The following is a description of a gene set: Genes in the cancer module 105. Human Gene Set: MODULE_105 studied in species Homo sapiens, and this is the list of marker genes: CCL21, SDF2, FGFR1, MKNK1, GBE1, LPIN2, CKS1B, EMG1 (EMG1 N1-specific pseudouridine methyltransferase), UBE2G1, BIRC5, VCAN, PRDX2, CRAT, S100A13, PDXK, PPP4R1, CCNF, PMP22 (peripheral myelin protein 22), DFFA, CDC34, GSPT1, PIGC, CITED2, CSRP2, RRM2, HSPB1, BLM, CTPS1, CITED1, CBR1, ANXA8L1, ADARB1, SLC20A1, COMP, POLD2, MRPL12, ERF, PLIN2, ASNS, MYBL2, UBXN1, NCBP2, THBS2, PCBD1, PFKFB4 (6-phosphofructo-2-kinase/fructose-2,6-biphosphatase 4), EZH2, IGF2BP3, POLR2J, PSMC2, PFKM, HSD17B10, NRIP1, SNX1, MGAT1, LTBR, TCF12, RBP1, SAA1, COL5A2, SNRPB2, GGH, CCNA2, ANXA1, CNN3, GPX2, LRBA, ACOT7, COX17, CARS1, COL4A2, DELE1, LPGAT1, AIMP2, GALC, PMAIP1, RAB4A, ATP2B1, MSMO1, FZD2, SNX17, MAPKAPK3, LMAN2, LAD1, KDM5C, CDK1, PHB1, WASF3, KCNK1 (NCBI Gene Id 3775), P3H4, KNTC1, PYGL, MAN2B1, MALL, FOXM1, GART, SRSF6, PFKP, RPA1, TPBG, TUBG1, FXYD3, CENPA, GTF2H1, PSEN1, HBEGF, SPARC, PCNA, ADAM9 (ADAM metallopeptidase domain 9), IDI1, NEK2, CSF1R, TLR1 (toll like receptor 1), CHAF1A, SREBF2, PPARD, ELAVL1, CLIP1, DDX17, AGXT, ILF3, ALCAM, KEAP1, ATF3, PAICS, PDLIM4, COG2, MELK, ARPC1A, GAS1, ZNF22, LUM, PRPSAP1, RRM1, WEE1, PAFAH1B3, DAP, NOLC1, ACTA2, MAD1L1, UMPS, CDH3, ERP29, HAGH, DNM2, TARBP2, FURIN, LAMB1, MSH2, COASY, MARK3, CCN2, MKI67, LAMA3, EMP1, BIRC2, LMO4, STIP1, P4HA1, MAD2L1, HADHA, PUM3, TOPBP1, NDUFB7, FADD (Fas associated via death domain), CACNB3, CHKA, PUF60, CCN1, RGS3, SUPT5H, CRYZ, BOP1, GOT2, NFYC, FAM3C, MTA1, PTS (NCBI Gene Id 5805), CYP1B1, DTYMK, COL6A3, SELENBP1, LGALS1, GJA1, HELZ, SOX4, THBS3, COL15A1, RO60, SERPINB5, MMD, HSPH1, ITPR3, COL3A1, ELANE, GCSH, COL18A1, MGMT, CCNB1, CKS2, AHR